The following is a description of a gene set: Miscellaneous substrates Human Gene Set: REACTOME_MISCELLANEOUS_SUBSTRATES studied in species Homo sapiens, and this is the list of marker genes: CYP4F3, CYP4A22, CYP2W1 (cytochrome P450 family 2 subfamily W member 1), CYP4F2, CYP4A11, CYP2D6, CYP2U1, CYP3A43, CYP4F11, CYP4F22, CYP2S1, CYP4B1